The following is a description of a gene set: Alpha 6 beta 4 signaling Human Gene Set: WP_ALPHA_6_BETA_4_SIGNALING species: Homo sapiens, and this is the list of marker genes: LAMA1, LAMB2, ITGA6, LAMA5, PRKCD, LAMA3, IRS2, LAMB1, GRB2, IRS1 (NCBI Gene Id 3667), MAPK14, LAMC2, HRAS, SOS1, LAMB3, PIK3R2, RAC1, EIF4EBP1, MAPK1, SHC1, RHOA, MTOR, PIK3R1, AKT1, LAMC1, PRKCA, GAB1, ITGB4, LAMA2, MAPK3, PTK2, PTPN11, SRC